The following is a description of a gene set: studied in species Mus musculus Genes down-regulated in AtT20 cells (pituitary cancer) after treatment with LIF. Leukemia inhibitory factor (LIF) mediates the hypothalamo-pituitary-adrenal stress response. Transgenic mice overexpressing LIF in the developing pituitary have altered pituitary differentiation with expansion of corticotropes, maintenance of Rathke's cleft cysts, and suppression of all other pituitary cell types. Affymetrix GeneChips were used to identify modulators of LIF effects in corticotrope (AtT-20) and somatolactotrope (GH(3)) cells. In addition to genes known to respond to LIF in corticotrope cells, corticotrope-specific changes were also observed for genes involved in glycolysis and gluconeogenesis, transcription factors, signaling molecules, and expressed sequence tags. Two transcription factors identified, CCAAT/enhancer-binding protein beta (C/EBPbeta) and glial cell-derived neurotrophic factor (GDNF)-inducible factor (GIF), dose-dependently induced expression of the rat POMC promoter when overexpressed in AtT-20 cells. LIF further induced POMC transcription with C/EBPbeta, but not with GIF. C/EBPbeta also induced expression of the SOCS-3 promoter that was further enhanced by cotreatment with LIF. However, GIF did not affect SOCS-3 expression. These results indicate that C/EBPbeta and GIF are downstream effectors of LIF corticotrope action. LIF also stimulates the expression of inhibitors of its actions, such as SOCS-3 and SH2 domain-containing tyrosine phosphatase-1. alpha(2)-HS-glycoprotein (AHSG)/fetuin, a secreted protein that antagonizes bone TGFbeta/bone morphogenic protein signaling, was induced by LIF in a signal transducer and activator of transcription-3-dependent fashion. Pretreatment with AHSG/fetuin blocked LIF-induced expression of the POMC promoter independently of SOCS-3. Thus, using GeneChips, C/EBPbeta and GIF have been identified as novel mediators and AHSG/fetuin as an inhibitor of LIF action in corticotropes. Human Gene Set: ABBUD_LIF_SIGNALING_1_DN from publication Abbud RA, Kelleher R, Melmed S (PMID 14576184), and this is the list of marker genes: BCKDHB, OSTF1, TSPAN7, ANKRD40, SYTL4, DCAF11, AHNAK, GRIA2, CYFIP1, KLRB1, HOXC9, DDC, SUCLA2, CAPN9 (NCBI Gene Id 51516), ITGA6, CD24, LIMS1, ALCAM, FOXA2 (forkhead box A2), EFNA2, ENPP2, STEEP1, REXO2, C16orf89, ARID1A, HK2, MTSS2, PELI1